The following is a description of a gene set: studied in species Homo sapiens from publication Dudziak D, Kamphorst AO, Heidkamp GF, Buchholz VR, Trumpfheller C, Yamazaki S, Cheong C, Liu K, Lee HW, Park CG, Steinman RM, Nussenzweig MC (PMID 17204652) Human Gene Set: GSE6259_33D1_POS_DC_VS_CD4_TCELL_DN Genes down-regulated in splenic CD 33D1+ dendritic cells versus CD4 T cells. Dendritic cells (DCs) process and present self and foreign antigens to induce tolerance or immunity. In vitro models suggest that induction of immunity is controlled by regulating the presentation of antigen, but little is known about how DCs control antigen presentation in vivo. To examine antigen processing and presentation in vivo we specifically targeted antigens to the two major subsets of DCs using chimeric monoclonal antibodies. Unlike CD8+ DCs that express the cell surface protein CD205, CD8- DCs, which are positive for the 33D1 antigen, are specialized for presentation on MHC class II. This difference in antigen processing is intrinsic to the DC subsets and associated with increased expression of proteins associated with MHC processing., and this is the list of marker genes: DMXL1, APOC2, MS4A14, CMKLR1, SCAMP1, GZF1, TLR8, IKBKE, PLOD1, GALC, DUSP1, MACF1 (NCBI Gene Id 649183), TYROBP, TIMP2, BLVRB, AOAH, LAMTOR3, DAGLB, GBP4 (guanylate binding protein 4), ITGAV, PLXNA4, SMAP2, GDPD1, SNX5, TCF7L2, GDE1, CALHM6, SLCO2B1, USP8, SLC11A1, KCNJ10, MYH10, SBF2, DSE, MGAT4A, PLA2G15, RGL1, EDNRA, FCHO2, LCP2, ITM2B, LAIR1, P2RY13 (NCBI Gene Id 53829), EVI5, ETV5, RCBTB2, DMXL2, MON2, ITGB5, CTSA, SCAMP5, LGALS9, HPGDS, FAM20C, GAMT, SVBP, ADGRE4P, RAB5C, FMN1, FAM83F, KLHL13, ZFYVE9, ACSL1, ARHGEF3, ADAM22, HNMT, PROS1, TMEM176A, INSR, NOVA1, ABCA1, MAF, ADAM17, MERTK, RUFY3, OPHN1, RASGRP1, EPHX1, CD72, SRC, C6, TMEM50A, LRP6, CD300LD, ABCA9, ERICH1, TBC1D10A, IRS2, SNX27, GAS7, SRFBP1, P2RX4, CD22, ADAM10, MYO7A, CTSZ, ATP13A3, SLF2, SYPL1, CP, APOE, SNX18, TBC1D2B, MIB1, TBK1, SELENOP, ZFAND5, PGAP1, COPZ2, TTYH2, MAFB, LPCAT2, AGMO, LGALS8, RAVER2, CD4, NCF2, CSF3R, PRUNE2, LY86, LIG4, MXRA8, APOBEC1, NPL, HPGD, CD38, P2RY12, NCEH1, HACD4, IGF1, RHOH, TCN2, PDGFC, ACP5, CTSO, TLR1, SASH1, GPNMB, HEBP1, TNFAIP3, DST, SH3KBP1, P2RY6, LAYN, TPP1, LRRC8A, VCAM1, ADAM9, CPEB4, MTUS1, GNS (NCBI Gene Id 2799), FCER1G, SLC28A2, SEMA4B, SAA3P, SEC14L1 (SEC14 like lipid binding 1), ITSN1, P2RX7, LST1, SERINC3, NUPR1, GBGT1, FCGR3A, PRKCB, FOXJ3, WWP1, OLFML3, CD84, CTSF, FGD4, MAN1C1, HK3, TMBIM4, PLD3, TMEM218, LGMN